Given this list of marker genes Clnk, Akr1b1, Srgn, Cxcr2, Tpsab1, Nppa, Anxa1, here is a description of the gene set: Mouse Gene Set: GOCC_MAST_CELL_GRANULE studied in species Mus musculus Coarse, bluish-black staining cytoplasmic granules, bounded by a plasma membrane and found in mast cells and basophils. Contents include histamine, heparin, chondroitin sulfates, chymase and tryptase.